The following is a description of a gene set: Genes negatively differentially expressed in cell type: γδ T cell upon treatment with cytokine: IL-7 in mouse lymph nodes in vivo. from publication Cui A, Huang T, Li S, Ma A, Pérez JL, Sander C, Keskin DB, Wu CJ, Fraenkel E, Hacohen N (PMID 38057668) Mouse Gene Set: CUI_T_CELL_GD_IL7_RESPONSE_DN species: Mus musculus Cytokines mediate cell-cell communication in the immune system and represent important therapeutic targets. A myriad of studies have highlighted their central role in immune function, yet we lack a global view of the cellular responses of each immune cell type to each cytokine. To address this gap, the authors created the Immune Dictionary, a compendium of single-cell transcriptomic profiles of more than 17 immune cell types in response to each of 86 cytokines (>1,400 cytokine-cell type combinations) in mouse lymph nodes in vivo. A cytokine-centric view of the dictionary revealed that most cytokines induce highly cell-type-specific responses. For example, the inflammatory cytokine interleukin-1β induces distinct gene programmes in almost every cell type. A cell-type-centric view of the dictionary identified more than 66 cytokine-driven cellular polarization states across immune cell types, including previously uncharacterized states such as an interleukin-18-induced polyfunctional natural killer cell state., and this is the list of marker genes: Hspa1b, Neat1, Plgrkt, Gimap1, Cd28, Btg2, Map4k4, Tspo, Ahnak, Ccdc88c, Faah, H2az2, Cd72, Taok1 (NCBI Gene Id 67240), Rnf167, Dap, Adgre5 (NCBI Gene Id 26364), Snx20, Cd27 (NCBI Gene Id 21940), Laptm5, Srpk2, Cd3g, 9930111J21Rik2, Paip2, Stap1, Rgs10, Tnfaip3, Sh3kbp1, Gramd1a, Txnip, Kif21b, Jun, Evl, Il18r1, Cdkn2d, Cd7, Ogt, Cxcr4, Ckb, Psap, Jak1, St3gal6, Gmfg (glia maturation factor, gamma), Klf2, Pnrc1, Pbxip1, Hmgb2, Dusp1, Arl5c, Zfp36l2, Aplp2, Wbp1, St6galnac3, Coq10b, Ablim1, Emb, Srgn, Ikzf2, Trp53inp1 (NCBI Gene Id 72576), Ctdsp2, Crlf3, Tspan32 (NCBI Gene Id 56845), Igf1r, Fchsd2, Myh9, Aak1, Tut4, Ipcef1, Cir1, Entrep3, Klf6, Ripor2, Acaa2, Klhl24, Acsbg1, Lsp1, Ash1l, Sh2d1a, Nlrc3, Tnrc6b (NCBI Gene Id 72625), Ramp3, Fth1, Itpkb, Ptpn18, Pdcd4, Mindy2, Tgfbr2, Il7r (NCBI Gene Id 223338), Cd3e, Gpsm3, Cyth4, Esyt2, Rapgef6, Rhob, Syne1, Cd96, Antkmt, Rgs2, Clk1, Junb, Cdc42ep3, Mtss1, Ramp1, Cited2, Hspa1a, Ighm, Ubc, Pcmtd2, Rsrp1, Sptssa, Arhgap45, Pik3ip1, S100a10, Ppp1r12a, Madd, Btg1 (NCBI Gene Id 380657), Cd3d, Pcmtd1, Aff4, Ttc28, Cenpa, Klrk1, Ctsd, St8sia4, Retreg1, Lims1, Uqcrh, Arhgef1, Aqp3, Mrtfa, Rb1cc1, Tsc22d3, S1pr1, Slc12a7, Cox7a2l, Hcst, Pde3b, Pink1, Cd52, Saraf, Ypel3, Setx, Mxd4, Tmem71, Gimap6, Neurl3, Tmem50a, Shisa5, Utrn, Trib2, Stim1, Git2, Arhgap15, Cmah, Krit1, Pfdn5, Tmem59, Smad7, Cd37, Smpdl3a, Gata3, Ptpre, Satb1, Prkacb, Crot, Fau, Txk, Stk17b, Crtc3, Bnip3l, Itm2b, Il16, Uba52, Elf1, Actn2, Fyb1, Ube2h, Cdkn1b, Sdc1, Tcf7